Given this list of marker genes Ptger3, Epdr1, Pdpn, Zeb2, Qki, here is a description of the gene set: Mouse Gene Set: GOBP_MYOFIBROBLAST_CONTRACTION species: Mus musculus The actin filament-based process in which cytoplasmic actin filaments slide past one another resulting in contraction of a myofibroblast.